Given this list of marker genes Usp9x, Snrpc, Tppp3, Zfand2a, Ccl5, S100a11, Itpr2, Scand1, Elf1, Tmsb10, Cmip, Apbb1ip, Tmed3, Ckb, Crip2, Ypel3, Cfl1, Ly6a, Trir, Lamp1, Gstm1, Ppib, Apoe, S100a4, Szrd1, Rbm39, Tbc1d17, Glud1, Dck, Tle5, Ubxn4, Pdcd6ip, Sf3b2, Grn, Tmsb4x, Ndufs1, Clu, S100a10, Ctla2a, Jund, Grb2, Cst3 (cystatin C), Fxyd5, Rap1a, Gadd45gip1, Nap1l4, Tmem160, Pfn1, Klf13, Plod1, Oaz1, Bptf, Nsg2, Txndc11, Nudt3 (NCBI Gene Id 68495), Sparc, Tle4, Rsrp1, Lgals1, Rpl13a, Ctsl, Sf3b5, Acss1, Lyz2, Clic1, Id3, Gpm6b, Csde1, Crip1, Prr13, Areg, Hsf1, Wdr3, Vim, Ap2s1, Cyba, Park7, S100a6, Cd3e, Ctsz, Timp2, Rnaset2b, Atp5mc2, Cotl1, Slmap (NCBI Gene Id 83997), Aup1, Qrich1, Nkg7, Gls, here is a description of the gene set: from publication Tabula Muris Consortium (PMID 32669714) Mouse Gene Set: TABULA_MURIS_SENIS_BROWN_ADIPOSE_TISSUE_T_CELL_AGEING species: Mus musculus